Given this list of marker genes Ppp3ca, Def8, Klf6, Ahsg, Mdk, Bcr, Cd38, Gpr137b, Syk, Tmem64, Src, P2rx7, Sfrp1, Gpr137, Gja1, Rock2, Ptger4, Iapp, Dlk1, Dcstamp, Adam8, Cd24a, Tmbim1, Lepr, Spp1, Hand2, Cldn18 (claudin 18), Prkca, Calcr, Il18, Trf, Agt, Idua, Lrp1, Oscar, Il20ra, Grem1, Ubash3b, Lrp6, Itgb3, Suco, Nf1, Thbs4, Fshr, Csk, Il6, Ceacam1, Ddr2, Tnfsf11, Syt7, Egfr, Fcgr4, Trp53, Pparg, Cartpt, Itgav, Mc4r, Tmem119, Rufy4 (NCBI Gene Id 435626), Inpp4b, Ltbp3, Gpnmb, Abr, Fshb, Rock1, Gata4, Inpp5d, Tfrc, Cst3, Ypel4, S1pr1, Flt4 (FMS-like tyrosine kinase 4), Car2, Arap1, Lep, Hrg, Fgfr3, Ppargc1b, Siglec15, Tnfrsf11a, Pdk4, Csf1r, Hamp (NCBI Gene Id 84506), Vegfa, Cyp19a1, Tnfrsf11b, Plekhm1, Slc4a2, here is a description of the gene set: Any process that modulates the frequency, rate, or extent of tissue remodeling. Mouse Gene Set: GOBP_REGULATION_OF_TISSUE_REMODELING studied in species Mus musculus